Given this list of marker genes LIG4, SDHB, DICER1, GCLC, FKBP6, PI4KA, BCOR, FCGR2A, RECQL4, UBR1, DACT1, DOCK2, PIGN, GTF2IRD1, SLC9A3, LTBP4, RAD51C, RNF43, PDE11A, RPS20, TGFBR2 (transforming growth factor beta receptor 2), PIGV, APC, PMS1, EFEMP1, TGFB1, PMS2, DDB1, MDM2, CCBE1, LONP1, BUD23 (BUD23 rRNA methyltransferase and ribosome maturation factor), MSH2, COL5A2, EDNRA, HCCS, METTL27, PTEN, PDGFRA, TP53, GTF2I, LIMK1 (LIM domain kinase 1), AXIN2 (NCBI Gene Id 8313), USF3, MLXIPL, CFTR, TCTN3, TCOF1, KEAP1, MID1, SPINT2, SEMA4A, CYBA, GTF2IRD2, RFC2, EPCAM, TTC7A, CEACAM6, AKT1, CHEK2, EIF4H, SDHD, SLC26A9, JAK3, TBL2, MIF, TMEM270, RNU12, HMOX1, CYBB, LMNA, MSH3, KIT, STAT3, SALL4 (spalt like transcription factor 4), BAZ1B, CLIP2, SDHC, KIF7, ITGB2, SRP68, NDUFB11, NAA10, CDKN2A, STK11, CLCA4, MSH6, IGHM (immunoglobulin heavy constant mu), NSUN2, CDK8, CCNQ, KLLN, ENG, VPS37D, ATM, GSTM3, BMPR1A, SLC6A14, SEC23B, SDHA, POLR1D, FREM1, DYM, DCTN4, POLE, MYH11, MKKS, POLR1B, CEACAM3, NTHL1, PRMT7, ZFX, VANGL1, KRAS, NCF2, PRKAR1A, STX1A, POLD1, BRCA2, FREM2, COL5A1, RAC2, MLH1, DNAJC30, PIK3CA (phosphatidylinositol-4,5-bisphosphate 3-kinase catalytic subunit alpha), SERPINA1, KCNN4, ELN, POLR1C, RPS6KA3, COX7B, SALL1 (spalt like transcription factor 1), MUTYH, MNX1, OTUD5, INSR, NCF1, HFE, GREM1, COL1A1, IL10RB, SMAD4, SLC11A1, here is a description of the gene set: studied in species Homo sapiens An abnormaltiy of the rectum, the final segment of the large intestine that stores solid waste until it passes through the anus. Abnormal rectum morphology Human Gene Set: HP_ABNORMAL_RECTUM_MORPHOLOGY